Given this list of marker genes SLC25A5, TPI1, ACP1, SPC25, CDC123, BCKDK, HAVCR2 (NCBI Gene Id 84868), CDKN3, DDX39A, CCNA2, SNF8, SPC24 (NCBI Gene Id 147841), CKAP2L, CKS1B, KIF22, MRPL42, GEN1, FLNB, STMN1, PSMA1, SDHB, STARD3NL, AFG3L1P, LSM12, SC5D, H2AC15, PBK, SURF4, FBXO5, CENPN, MRPL46, PLK1, CINP, IL1B, COPS4, HAUS1, CCNB2, CDCA8, IFITM1, HMMR, SSR2, SLC25A13, NUF2, PRIM1, ZBTB32, SNRPA1, KIF15, UCK2, CDC45, TKT, RIPK3, MKI67, LAP3, NME1, IMPA2, SHMT2, PMPCB, HMGN2, ISOC1, DCK, GMNN, SLC16A3, ORC6, SHMT1, AGPAT5, RAN, TCEAL9, CDK1, MIS18BP1, CENPS (NCBI Gene Id 378708), RANBP1, MRPS18A, RRM2, ARSB, BUB1, EIF1AD, ASF1B, PRIM2, NDC1, POLR3K, MYL4, LYAR, PSMD6, FKBP2, RAD51AP1, H2BC3, BIRC5, EIF2S2, LSM3, KNL1, PMM1, CKS2, MRPL18, AURKA, PSMC3, SPDL1, CDC14A, CYP20A1, RAD51, UPK1A, CCRL2, JPT2, MCM7, DPAGT1, AURKB, H4C14, ETFB, MAD2L1, DBI, TRIP13, TFDP1, FIGNL1, TNFRSF9, MRTO4, RCC1, MARS1, TIMM17A, EME1, PSAT1, NME7, PNO1, PIGT, IRF4, C1D, HIRIP3, FAM136A, TUBGCP2, GZMK, NANS, SGO1, SYCE2, PSMA5, CSTF2, CDK4, TUBG1, H1-1, PRKAG1, LGALS1, DUT, NRM, ROM1, H2AX, GGT1, BUB3, ACADL, MDH2, CSF3R, HAT1 (histone acetyltransferase 1), ALYREF, LSM2, TROAP, ADAP1, FAM72A, DSCC1, UBE2S, ANXA2, PRELID1, GINS1, RBBP7, UBE2N, RFC3, ERH, CENPP, POLE2, SPAG5, COPS3 (NCBI Gene Id 8533), UGP2, PRMT7, PSMB2 (NCBI Gene Id 5690), CDCA3, CCDC34, DEPDC1, PSMD12, COPS5, MCM10 (minichromosome maintenance 10 replication initiation factor), PLAC8, MTX1, PSMC3IP, SFXN1, NHP2, VIM, PPA1, IDI1, TUBB4B, here is a description of the gene set: Human Gene Set: GSE13547_2H_VS_12_H_ANTI_IGM_STIM_BCELL_DN studied in species Homo sapiens Genes down-regulated in B lymphocytes stimulated by anti-IgM: 2h versus 12h. from publication Arenzana TL, Smith-Raska MR, Reizis B (PMID 19329779) The development, homeostasis and function of B lymphocytes involve multiple rounds of B cell receptor (BCR)-controlled proliferation and prolonged maintenance. We analyzed the role of transcription factor Zfx, a recently identified regulator of stem cell maintenance, in B cell development and homeostasis. Conditional Zfx deletion in the bone marrow blocked B cell development at the pre-BCR selection checkpoint. Zfx deficiency in peripheral B cells caused impaired generation of the B-1 cell lineage, accelerated B cell turnover, depletion of mature recirculating cells, and delayed T-dependent antibody responses. Zfx-deficient B cells showed normal proximal BCR signaling, but impaired BCR-induced proliferation and survival. This was accompanied by aberrantly enhanced and prolonged integrated stress response, and delayed induction of Cyclin D2 and Bcl-xL proteins. Thus, Zfx restrains the stress response and couples antigen receptor signaling to B cell expansion and maintenance during development and peripheral homeostasis.